The following is a description of a gene set: Regulation of GF-RTK-RAS-ERK signaling, SPRED and NF1. Pathway ID: N01597. Pathway type: Reference. Pathway class: nt06526 MAPK signaling. Pathway Definition from KEGG: (SPRED+NF1) -| RAS studied in species Homo sapiens Human Gene Set: KEGG_MEDICUS_REFERENCE_REGULATION_OF_GF_RTK_RAS_ERK_SIGNALING_SPRED_AND_NF1, and this is the list of marker genes: SPRED1, HRAS, NRAS (NCBI Gene Id 4893), SPRED2, NF1, KRAS